The following is a description of a gene set: species: Mus musculus Any process involved in the maintenance of an internal steady state of sterol within an organism or cell. Mouse Gene Set: GOBP_STEROL_HOMEOSTASIS, and this is the list of marker genes: Xbp1, Abcd1, Ces1g, Mia2, Pnliprp1, Ces1e, Malrd1, Ehd1, Plscr3, Washc5, Pnliprp2, Nr1h3, Ephx2, Ncor1, Dgat2, Insig1, Soat1 (NCBI Gene Id 98715), Nr1h4, Ldlr, Nus1, Npc1, Fabp3 (fatty acid binding protein 3, muscle and heart), Acox1, Sec24a, Tsku, Soat2, Fgfr4, Mir33, Lima1, Nr1h2, Ces1d, Abca2, Mylip, Pcsk9, Lcat, Ldah, Ttc39b, Negr1, Ttc39d, Apoa4, Cyp7a1, Hsdl2 (NCBI Gene Id 72479), Abcg1, Abca1, Gpr39, Pnlip, Apoa2, Cyp7b1 (cytochrome P450, family 7, subfamily b, polypeptide 1), Ces1h, Rora, Ces1c, Cd24a, Srebf2, Apob, Commd1, Lipg, Med13, Tspo, Gpihbp1, Tmem97, Slc37a4, Alms1, Ces1b, Apoa5, Ces1a, Cyp39a1, Abcg8, Mexis, Npc2, Abcb11, Cav3, Lamtor1, Lrp5, Scd1 (NCBI Gene Id 20249), Cav1, Sirt1, G6pc1, Lipc, Ampd2, Abcg4, Gramd1b, Ccdc22, Apoc3, Apoa1, Hnf4a, Commd9, Ldlrap1, Il18, Mttp, Nr5a2, Nr1d1, Hdac9 (NCBI Gene Id 79221), Apoe, Slco1a6, Scarb1, Nfe2l1, Abcg5, Errfi1, Mir124a-1hg, Pla2g10, Lpl, Ces1f, Raly, Pla2g12b, Fabp4, Hpn, Npc1l1, Abca5, Angptl3, Minar2, Pex2